Given this list of marker genes CLASP1, SATB1, RUBCN, DDR1, ADCY9, FSCN1, SMARCC1, TP53I11, SLC20A2, SRSF6, DUSP6, ARHGAP1, IDI1, TPM2, SECISBP2L, CHD4, CTBP2, MFSD10, SLC35E2B, MAP1A, CCND1, ATP10B, POMK, ZC3H14, TNFRSF10B, GOLGA8A, SERPINA1, GUSBP14, NKX2-1, USP6, SLC7A8, GABBR2, ATP13A3, RDH11 (NCBI Gene Id 51109), SEPTIN9, APLP2, LASP1, EVPL (NCBI Gene Id 2125), SOX4, EID1, IL1R1, FBN1, RAPGEF3, TULP3, DYNC2LI1, SFPQ, EPOR, here is a description of the gene set: Human Gene Set: LUI_THYROID_CANCER_PAX8_PPARG_UP The demonstration of the PAX8-PPAR(gamma) fusion oncogene in a subset of follicular thyroid tumors provides a new and promising starting point to dissect the molecular genetic events involved in the development of this tumor form. In the present study, we compared the gene expression profiles of follicular thyroid carcinomas (FTCs) bearing a PAX8-PPAR(gamma) fusion against FTCs that lack this fusion. Using unsupervised clustering and multidimensional scaling analyses, we show that FTCs possessing a PAX8-PPAR(gamma) fusion have a highly uniform and distinct gene expression signature that clearly distinguishes them from FTCs without the fusion. The PAX8-PPAR(gamma)(+) FTCs grouped in a defined cluster, where highly ranked genes were mostly associated with signal transduction, cell growth and translation control. Notably, a large number of ribosomal protein and translation-associated genes were concurrently underexpressed in the FTCs with the fusion. Taken together, our findings further support that follicular carcinomas with a PAX8-PPAR(gamma) rearrangement constitute a distinct biological entity. The current data represent one step to elucidate the molecular pathways in the development of FTCs with the specific PAX8-PPAR(gamma) fusion. studied in species Homo sapiens Top up-regulated genes distinguishing between follicular thyroid carcinoma (FTC) samples by the presence or absence of the PAX8-PPARG fusion protein. from publication Lui WO, Foukakis T, Lidén J, Thoppe SR, Dwight T, Höög A, Zedenius J, Wallin G, Reimers M, Larsson C (PMID 15608688)